The following is a description of a gene set: Human Gene Set: GOBP_COPII_COATED_VESICLE_BUDDING The evagination of an endoplasmic reticulum membrane, resulting in formation of a COPII-coated vesicle. studied in species Homo sapiens, and this is the list of marker genes: PPP6C, RAB1A, TRAPPC8, CIDEB (NCBI Gene Id 27141), TRAPPC4, TRAPPC12, SEC24A, TFG, SAR1B, TRAPPC3, SCAP, TMED10, TRAPPC2B, TRAPPC2L, SURF4, SEC23B, VAPB, PEF1, SEC31B, MIA3, TBC1D20, SEC13, SEC24D, TRAPPC11, SEC24B, CSNK1D, CUL3, TRAPPC1, KLHL12, SEC24C, TRAPPC2, MAPK15, TRAPPC5, VAPA, TRAPPC6A, INSIG1, SEC31A, SAR1A, PREB, SEC23A, PDCD6, TMED2, SEC16A